Given this list of marker genes PSMD11, TXNRD1, KRT8, TSPAN1, UBE2M, IER3, MALL, PSMD13, PSMD8 (NCBI Gene Id 5714), MAGEA6, DUSP14, FERMT2, CKAP4, HSPA4, GDF15, CDK2AP2, MAGEA4, POU5F1, CAPNS1, ILF3, ANXA2, TFAP2C, MAGEA3, TUBB2A, HRAS, CCND1, H4C9, STIP1, GPRC5A, here is a description of the gene set: from publication Hofmann WK, de Vos S, Komor M, Hoelzer D, Wachsman W, Koeffler HP (PMID 12411319) Genes down-regulated in bone marrow hematopoietic stem cells (HSC, CD34+) from patients with low risk of myelodysplastic syndrome (MDS) compared with healthy controls. species: Homo sapiens Gene patterns of expression in purified CD34(+) bone marrow cells from 7 patients with low-risk myelodysplastic syndrome (MDS) and 4 patients with high-risk MDS were compared with expression data from CD34(+) bone marrow cells from 4 healthy control subjects. CD34(+) cells were isolated by magnetic cell separation, and high-density oligonucleotide microarray analysis was performed. For confirmation, the expression of selected genes was analyzed by real-time polymerase chain reaction. Class membership prediction analysis selected genes. Using the expression profile of these genes, we were able to discriminate patients with low-risk from patients with high-risk MDS and both patient groups from the control group by hierarchical clustering (Spearman confidence). The power of these genes was verified by applying the algorithm to an unknown test set containing expression data from 8 additional patients with MDS (3 at low risk, 5 at high risk). Patients at low risk could be distinguished from those at high risk by clustering analysis. In low-risk MDS, we found that the retinoic-acid-induced gene (RAI3), the radiation-inducible, immediate-early response gene (IEX1), and the stress-induced phosphoprotein 1 (STIP1) were down-regulated. These data suggest that CD34(+) cells from patients with low-risk MDS lack defensive proteins, resulting in their susceptibility to cell damage. In summary, we propose that gene expression profiling may have clinical relevance for risk evaluation in MDS at the time of initial diagnosis. Furthermore, this study provides evidence that in MDS, hematopoietic stem cells accumulate defects that prevent normal hematopoiesis. Human Gene Set: HOFMANN_MYELODYSPLASTIC_SYNDROM_LOW_RISK_DN